Given this list of marker genes NLRP1, SMAD2, EPHB4, TGFBR2, MBTPS2, COL6A2, PLOD1, LEMD3, IPO8, EBP, TFAP2A, LAMC2, COL6A3, C1R, PLEC, B3GALT6, CPOX, CTSC, ADAMTS2, COL7A1, COL1A1, COL12A1, FLNA, KRT14, TNXB, ZNF469, TGFB2, OCRL (NCBI Gene Id 4952), GJB6, COL3A1, SLC39A13, CHST14, RHOA, KDF1, TGFB3, ITGB4, COL5A2, DSE, LAMB3, LRP1, FKBP14, APC, UROS, NOTCH3, MMP1, CLDN1, KRT5, SMAD3, LAMA3, GJB2, ADA2, EP300, UROD, COL5A1, LSS (NCBI Gene Id 4047), THBS2, PDGFRB, DST, AEBP1, COL17A1, NCSTN, ERCC8, GATA1, TGFBR1, FERMT1, C1S, COL6A1, B4GALT7, ATP7A, MAP3K7, COL1A2, NTRK1, CARMIL2, ERCC6, CREBBP, here is a description of the gene set: Human Gene Set: HP_ATYPICAL_SCARRING_OF_SKIN species: Homo sapiens Atypically scarred skin. Atypical scarring of skin